The following is a description of a gene set: Establishment of cohesion. Pathway ID: N01484. Pathway type: Reference. Pathway class: nt06512 Chromosome cohesion and segregation. Pathway Definition from KEGG: STAG1,STAG2 == PDS5+WAPL -> CDCA5,CTCF == STAG+PDS5+WAPL Human Gene Set: KEGG_MEDICUS_REFERENCE_ESTABLISHMENT_OF_COHESION studied in species Homo sapiens, and this is the list of marker genes: WAPL, PDS5A, PDS5B, STAG1, STAG2, CDCA5, CTCF